Given this list of marker genes Cd44, Ndrg2, Gfap, Mlc1, Klf15, Aldh1l1, here is a description of the gene set: from publication Bedogni F, Hevner RF (PMID 34321999) species: Mus musculus Genes selectively expressed by astrocytes in embryonic day 14.5 mouse telencephalon. Mouse Gene Set: HEVNER_TELENCEPHALON_ASTROCYTES